Given this list of marker genes CITED2, PITX2, TFAP2C, TFAP2A, here is a description of the gene set: Reactome Pathway: TFAP2 (AP-2) family regulates transcription of other transcription factors Homodimers and possibly heterodimers of TFAP2A and TFAP2C, in complex with CITED2, stimulate transcription of the PITX2 gene, involved in left-right patterning and heart development. part of: Transcriptional regulation by the AP-2 (TFAP2) family of transcription factors studied in species Homo sapiens